Given this list of marker genes IDH3G, IDH3A, IDH3B, IDH2, IDH1, here is a description of the gene set: Human Gene Set: GOMF_ISOCITRATE_DEHYDROGENASE_NAD_P_PLUS_ACTIVITY studied in species Homo sapiens Catalysis of the reaction: isocitrate + NAD(P)+ = 2-oxoglutarate + CO2 + NAD(P)H.